The following is a description of a gene set: The compaction of chromatin into heterochromatin at the subtelomeric region. studied in species Mus musculus Mouse Gene Set: GOBP_SUBTELOMERIC_HETEROCHROMATIN_FORMATION, and this is the list of marker genes: H3f3a, Dot1l, Hat1, Sirt6, Rif1, Ezh2, Atrx, Ezh1, H3f3b